The following is a description of a gene set: Genes in the cancer module 128. studied in species Homo sapiens Human Gene Set: MODULE_128, and this is the list of marker genes: CCR1, FAP, IL32, CXCR6, TIMP3, SRRM2, IFI30, CD14, IFITM2, DCTN3, TBC1D8B, CCL2, APOL3, CYBB (cytochrome b-245 beta chain), CCL11, IFITM3, ZNF347, PCDH9, FTH1, A2M, FCGR2A, S100A4, TNFSF13, VCAM1, CXCL9, VMP1, HLA-DOA, KCTD12, CYP1B1, AIF1, FADS1, CTSL, IER3, GBP2, CCL18, PLPP3, DAB2, DLC1, IL1R1, MMP9, CD151, CSF1R, TYROBP, LMO2, MMP1, FPR1, FTL, TNFAIP6, CTSB, THBS1, FCER1G, MGLL, MYLK, FCGR1A, VWF, C3AR1, IL2RB, GBP1, CXCL12, TIMP2, ITGB2, CCR5, CCND2, LGMN (legumain), DAPK1, MAPK12, TIMP1, GJB1, DES, CEBPD, LAG3, CYP27A1, CPM, PDGFRB, CD63, CCL5, GZMK, BBS2, ITGB5, NXPH3, CCL14 (NCBI Gene Id 6358), CCR2, CCL21, EARS2, GNLY, GAS6, CDH13, IFITM1, GPX1, FN1, HBA2, SPARC, VIM (vimentin), PDGFRA, LYZ, CCN1, MMP2